The following is a description of a gene set: Reactome Pathway: SHC1 events in ERBB2 signaling studied in species Mus musculus This event has been computationally inferred from an event that has been demonstrated in another species.<p>The inference is based on the homology mapping from PANTHER. Briefly, reactions for which all involved PhysicalEntities (in input, output and catalyst) have a mapped orthologue/paralogue (for complexes at least 75% of components must have a mapping) are inferred to the other species. part of: Signaling by ERBB2 electronically inferred by orthology from the curated human pathway, and this is the list of marker genes: Erbb2, Egfr, Erbb4, Prkca, Btc, Ptpn12, Nrg3, Shc1